The following is a description of a gene set: part of: Processing of Capped Intron-Containing Pre-mRNA Reactome Pathway: Transport of Mature Transcript to Cytoplasm electronically inferred by orthology from the curated human pathway This event has been computationally inferred from an event that has been demonstrated in another species.<p>The inference is based on the homology mapping from PANTHER. Briefly, reactions for which all involved PhysicalEntities (in input, output and catalyst) have a mapped orthologue/paralogue (for complexes at least 75% of components must have a mapping) are inferred to the other species. studied in species Mus musculus, and this is the list of marker genes: Fip1l1, Thoc3, Nup133, Thoc7, Nup210, Wdr33, Nxf2, Magohb, Nup85, Nup205, Slbp, Rae1, Nxf7, Seh1l, Ddx39a, Cdc40, U2af2, Cpsf3, Srsf5, Aaas (achalasia, adrenocortical insufficiency, alacrimia), Sarnp, Nup93, Cpsf1, U2af1l4, Nup42, Nup58, Ndc1, Magoh, Upf3b, Nup54, Alyref, Srsf3, Casc3, Rnps1, Nup155, Thoc6